The following is a description of a gene set: Mouse Gene Set: GOMF_GLUTATHIONE_TRANSMEMBRANE_TRANSPORTER_ACTIVITY species: Mus musculus Enables the transfer of glutathione, the tripeptide glutamylcysteinylglycine, from one side of a membrane to the other., and this is the list of marker genes: Abcc1, Abcc4, Abcc5, Gja1, Slc25a39, Slc13a3, Slc25a40